The following is a description of a gene set: Human Gene Set: GOBP_CHEMOREPULSION_OF_AXON studied in species Homo sapiens The process in which a neuron growth cone is directed to a specific target site in response to a repulsive chemical cue., and this is the list of marker genes: WNT5A, RYK, SEMA3B, UNC5C, PLXNA4, NTN1